Given this list of marker genes Rarb, Scube2, Trpv4, Col27a1, Poc1a, Hoxd11, Nppc, Mmp13, Matn1, Col9a1, Tgfbr2, Hspg2, Smpd3, Dspp, Npr2, Thbs3, Carm1, Por, Col2a1, Hoxa11, Sik3, Stc1, Rarg, Zmpste24, Cst5, Cer1, Rara, Ift80, Cbs, Atf2, Shox2, Thbs1, Col1a1, Ihh, Comp, Fosl2, Axin2, Trip11, Ext1, Serpinh1, Sox9, here is a description of the gene set: Mouse Gene Set: GOBP_CARTILAGE_DEVELOPMENT_INVOLVED_IN_ENDOCHONDRAL_BONE_MORPHOGENESIS The process whose specific outcome is the progression of the cartilage that will provide a scaffold for mineralization of endochondral bones. studied in species Mus musculus